Given this list of marker genes ATG3, ERBB4, BAX, DNM1L, CCAR2, FIS1, BNIP3, NPTX1, VPS35, PRKN, here is a description of the gene set: species: Homo sapiens Human Gene Set: GOBP_MITOCHONDRIAL_FRAGMENTATION_INVOLVED_IN_APOPTOTIC_PROCESS The change in the morphology of the mitochondria in an apoptotic cell from a highly branched network to a fragmented vesicular form.